Given this list of marker genes RYR3, ITIH3, LDB3 (LIM domain binding 3), SULT4A1, ADAMTSL3, PTPRB, FAM110B, PHLDB1, CYP2C19, SLC15A1, KLRC4, TNIK, IFNA10, AOC4P, DNAJC22, COL14A1, MLLT10, GRIK1, NEB, GHRHR, R3HCC1L, GLRA3, PPM1E, P2RY10, KRT2, CRIPTO, POU6F1, RNF24, SERPINA4, CFH, PSG1, SMYD3, ATP4B, MINDY2, FAM13A, PART1, SPRR2C, RXRG, PHOX2B, IL11RA (NCBI Gene Id 3590), RORB, SGCD, NHEJ1, DDX52, PAX6, FLRT2, APOBEC1, COL19A1, PGM3, MC5R, RB1CC1, PLPPR4, CMKLR2, MAGEA8, CTRL, PHF10, IPO9, ZNF157, HCRTR2, COQ7, ZSCAN26, RREB1, THPO, CEP162, CNTN6, HSD3B2, CAMTA1, AMMECR1, MAGEA9, PIK3C2A, COL8A1, ADRA1A, CADM4, ZNF141, TBX19, ST8SIA1, LRP4, STAC, LECT2, DBT, MAP3K1, NR1I2, FZD5, GJB5, TENM4, PVR, ABCB1, IFNA14, CRHR1, SUPT3H, DMD, IFNA1, PTPN20, CPB2, LGI1, TTTY1, NR3C2, HTR1E, RBMXL1, IFNW1, RAD51D, BMP10 (bone morphogenetic protein 10), GPR18, NPFF, HNF1A, B4GALT6, EPHB2, GPR19, CACNA2D1, IL7, GNG4, CLCN3, ADGRL2 (adhesion G protein-coupled receptor L2), IFNA2, ATF2, LORICRIN, JADE3, IGKV7-3, SLC46A3, FSHR, ZNF202, CPEB3, FOSL1, EYA1 (EYA transcriptional coactivator and phosphatase 1), BRINP3, ATXN3 (NCBI Gene Id 4287), GCM1, EDIL3, FUT1, ADAM20, AQP7, PCM1, ZBTB14, CAMK4, GUCY2F, TBXT, OR10H3, CDC73, HEPH, SIX6, MYT1, ERCC4, FBXL4, OR2B6, MDM2, CXCL5, GABRB2, POLR1HASP, F2RL1 (NCBI Gene Id 7901), JRKL, CDR1, KRT34, TLL1, ITGBL1, DRD1, NTNG2, MAP2, CTSB, PDE6A, IL16, ABO, DMPK, EXOC4, SLC33A1, POU6F2, UBE4B, ZBTB40, SPA17, LILRA1, PRKCA, PDE4D, TSSK2, SLC4A8, GPR171, TANC2, SLC6A2, ZNF132, ABCB10, CHRNB4, CDC42BPA, CYP2E1, here is a description of the gene set: Neighborhood of PRKCA protein kinase C, alpha in the MORF expression compendium Neighborhood of PRKCA Human Gene Set: MORF_PRKCA studied in species Homo sapiens